Given this list of marker genes Lgals3, Fgr, Ighg2c, Ighg2b, Ighg3, Ighg1, Flna, here is a description of the gene set: species: Mus musculus Mouse Gene Set: GOMF_FC_GAMMA_RECEPTOR_I_COMPLEX_BINDING Binding to one or more specific sites on the Fc-gamma receptor I complex. The complex functions primarily as an activating receptor for IgG.